The following is a description of a gene set: Human Gene Set: AIYAR_COBRA1_TARGETS_UP Genes up-regulated in T47D cells (breast cancer) after COBRA1 knockdown by RNAi. Eucaryotic genes that are coordinately expressed tend to be clustered. Furthermore, gene clusters across chromosomal regions are often upregulated in various tumors. However, relatively little is known about how gene clusters are coordinately expressed in physiological or pathological conditions. Cofactor of BRCA1 (COBRA1), a subunit of the human negative elongation factor, has been shown to repress estrogen-stimulated transcription of trefoil factor 1 (TFF1 or pS2) by stalling RNA polymerase II. Here, we carried out a genome-wide study to identify additional physiological target genes of COBRA1 in breast cancer cells. The study identified a total of genes that were either activated or repressed upon small hairpin RNA-mediated reduction of COBRA1. Interestingly, many COBRA1-regulated genes reside as clusters on the chromosomes and have been previously implicated in cancer development. Detailed examination of two such clusters on chromosome 21 (21q22) and chromosome X (Xp11) reveals that COBRA1 is physically associated with a subset of its regulated genes in each cluster. In addition, COBRA1 was shown to regulate both estrogen-dependent and -independent transcription of the gene cluster at 21q22, which encompasses the previously identified COBRA1-regulated TFF1 (pS2) locus. Thus, COBRA1 plays a critical role in the regulation of clustered gene expression at preferred chromosomal domains in breast cancer cells. studied in species Homo sapiens from publication Aiyar SE, Blair AL, Hopkinson DA, Bekiranov S, Li R (PMID 17043641), and this is the list of marker genes: SERPINA3, ASNS, IFITM1, GAGE1, TOMM20, AREG, MGP, DNAL4, PIP, PARP4, C1orf159, METTL25B, CTSB, FHL2, ASS1, TMEM50A, MBTPS1 (NCBI Gene Id 8720), DEGS1, NENF, ENAH, CLDN1, TPBG, PBRM1, TFF3, EPRS1, APOD, SLC52A2, FBXL6, ACOX2, PRLR, MAPK8IP2, S100A8, TRIB3, FRS2, PRCP, SATB1, GADD45A, NEK2, TIMP1, UBL3